The following is a description of a gene set: Human Gene Set: GOBP_GLYCEROPHOSPHOLIPID_CATABOLIC_PROCESS The chemical reactions and pathways resulting in the breakdown of glycerophospholipids, any derivative of glycerophosphate that contains at least one O-acyl, O-alkyl, or O-alkenyl group attached to the glycerol residue. species: Homo sapiens, and this is the list of marker genes: PLA2G4B, GPCPD1 (glycerophosphocholine phosphodiesterase 1), APOC1, LDLR, GDPD3, PLA2G6 (NCBI Gene Id 8398), PLA2G10, PLA2G4C, PLB1, PLA2G5, PLA2G4D, ABHD12, ENPP2, PNPLA6, PLA2G4F, LIPC, PLA2G4E, PNPLA8, ABHD16B, PLCB1, PRDX6, PLA2G4A, PLA2G15, ENPP6, PLA2G7, SMPD4, INPP5F, GDPD1, ABHD16A, SCARB1, GDE1, PNLIPRP2, PNPLA7 (NCBI Gene Id 92716), ABHD12B